The following is a description of a gene set: Human Gene Set: GSE27786_NKTCELL_VS_NEUTROPHIL_DN from publication Konuma T, Nakamura S, Miyagi S, Negishi M, Chiba T, Oguro H, Yuan J, Mochizuki-Kashio M, Ichikawa H, Miyoshi H, Vidal M, Iwama A (PMID 21540074) Each fraction of mouse hematopoietic cells was purified by cell sorting from bone marrow of 8-week-old C57BL/6 mice, and its gene expression was analyzed. species: Homo sapiens Genes down-regulated in comparison of NKT cells versus neutrophils., and this is the list of marker genes: MCEE, ADIPOR2, FBXL19, MSN, MAP3K3, STRN3, CSMD3, DCLRE1A, AQP9, HSD17B7, CHRM3, LDB2, TMEM50A, MYL3, FDFT1, PTPN1, STAT3, HSPBAP1, ZNF236, PRSS45P, ENPP2, SCN1A, INCENP, PPOX, CPEB2, RAP1B, PTS, MAEA, RAB14, PRKAB1, CHSY3, GPR146 (NCBI Gene Id 115330), BRD9, RSAD2, AGTPBP1 (NCBI Gene Id 23287), SEMA3G, SOCS3, LPCAT1, GALNS, HPS5 (NCBI Gene Id 246309), SALL3, ADAM28, ATG2A, STARD5, TTLL3, TFEB, RGS6, VPS4B, IQSEC1, PLP1, TRPM2, ABCD1, LGALS9B (galectin 9B), SERPINF1, TMEM100, TMEM63A, GALNT9 (NCBI Gene Id 729185), NCOA6, ARHGAP19, ATP11B, VN1R5, PPP2R5A, TRAPPC11 (trafficking protein particle complex subunit 11), HPN, SLC16A6, SSC4D, ARMC3, PTH2, HCLS1 (NCBI Gene Id 3059), SLC30A2, RIOX1, NFASC, CYP2C18, CAPNS1, CACNG4, P2RY13 (purinergic receptor P2Y13), TIAM2, FAT3, TRAPPC6B, TRAPPC5, HERPUD2, ATP6V1C2, ZFAND5, CHM, WNT9B, IFT57, PRELID3B, RASGRP2, TMC4, ULK1, ARL3, STRADB, XBP1, TMX3, C22orf23, YPEL5, TSTD2, STK4, EPHA2, GPRC5C, DNMT3L, PITHD1, NKAIN1, SORBS3, FZD7, FOXN2, ARPC1A, VPS13D, TP53INP1, RAD51D (RAD51 paralog D), ACADM, RAF1, GOT1L1, CMTM7, GLIPR1, EIF4E3, SMIM7, FBXO3, VPS13B, TST, CST3, ELOVL1, ARID3B, KCNC2, TEKT5, DOC2A, ARMCX6, CDC14A, RGCC, TRAK2, CPA5, STK32B, ZDHHC4, GADD45B, PRC1, H2AX, ADAMTS5, SERF2, PRSS55, BMP10, AKT2, UBL5, RFLNA, TAF12, PRSS50, AURKA, NAAA, DNAAF9, SUSD1, KLC3, HNRNPLL, ZNF516, CCDC88C, SORD, PCYT1A, ZNF652, STS, STXBP5, TMEM165, TNFRSF1A, PPP2CB, PABIR1, IL1RAP, MYL7, CITED1, TMEM30A, NR1H2, KCTD10, LDLRAP1, SUSD3, SNED1, MDM2, GCK, PELI2, KCND1, ASPHD1, SLC7A11, RAB3GAP2, COX19, KLF7, SCAMP2, DOCK1, NRP1, KRT80, GPD2 (glycerol-3-phosphate dehydrogenase 2), B4GALNT4, TAT, UFD1, RIT1, KLHL12, OSBPL7, MAP3K20, ACOX2, IGLC7, ERLIN2 (ER lipid raft associated 2), GREM2, F10, CLN3, CAPZB, SHC1